The following is a description of a gene set: species: Mus musculus electronically inferred by orthology from the curated human pathway Reactome Pathway: Biosynthesis of E-series 18(R)-resolvins part of: Biosynthesis of EPA-derived SPMs This event has been computationally inferred from an event that has been demonstrated in another species.<p>The inference is based on the homology mapping from PANTHER. Briefly, reactions for which all involved PhysicalEntities (in input, output and catalyst) have a mapped orthologue/paralogue (for complexes at least 75% of components must have a mapping) are inferred to the other species., and this is the list of marker genes: Gpx4, Alox15, Lta4h